The following is a description of a gene set: species: Mus musculus Mouse Gene Set: GOBP_REPLACEMENT_OSSIFICATION Ossification that requires the replacement of a preexisting tissue prior to bone tissue formation., and this is the list of marker genes: Mmp16, Bmp4, Col2a1, Bmp6, Enpp1, Dlx5, Col1a1, Alpl, Sik3, Fgf18, Ift80, Bpnt2, Csgalnact1, Hspg2, Inppl1 (inositol polyphosphate phosphatase-like 1), Nab1, Npr2, Mef2c, Nfix, Phospho1, Cst5, Smpd3, Col13a1, Ext1, Pex7, Tmem119, Mmp13, Cbs, Galnt3, Scx, Pthlh, Col10a1, Foxc1, Runx2, Mef2d, Nab2, Mmp14, Gnas